Given this list of marker genes ILK (integrin linked kinase), PACSIN2, RFTN1, IQGAP1, EMP2, ANXA2, COL6A1, MIR138-1, CAV3, FLOT1, LRCH4, CAV2, S100A10, CAV1, here is a description of the gene set: studied in species Homo sapiens Human Gene Set: GOBP_MEMBRANE_RAFT_ASSEMBLY The aggregation, arrangement and bonding together of a set of components to form a membrane raft, a small (10-200 nm), heterogeneous, highly dynamic, sterol- and sphingolipid-enriched membrane domains that compartmentalizes cellular processes.